Given this list of marker genes Il2ra, Csf2, Grb2, Stat5a, Rps27a, Il2rb, Shc1, Inppl1, Ubb, Il5, Ptpn6, Csf2rb, Cbl, Prkaca (protein kinase, cAMP dependent, catalytic, alpha), Il5ra, Crk, Stat5b, Jak3, Fyn, Vav1, Il3, Il2rg, Syk, Il2 (NCBI Gene Id 16183), Pik3cb, Yes1, Pik3r2, Tec, here is a description of the gene set: This event has been computationally inferred from an event that has been demonstrated in another species.<p>The inference is based on the homology mapping from PANTHER. Briefly, reactions for which all involved PhysicalEntities (in input, output and catalyst) have a mapped orthologue/paralogue (for complexes at least 75% of components must have a mapping) are inferred to the other species. part of: Signaling by Interleukins species: Mus musculus electronically inferred by orthology from the curated human pathway Reactome Pathway: Interleukin-3, Interleukin-5 and GM-CSF signaling